Given this list of marker genes YME1L1, DHX15, RBM25, CSNK1A1, SERBP1, UBR7, ARL8B, OTUD4, ANKRD17, SEC22C, MED17, TBC1D15, LARS1, POLDIP3, RSRC2, OCIAD1, FOXJ3, EHBP1, EIF3J, LUC7L2, PRPF8, TOR1AIP1, CHTOP, DMTF1, HIPK1, ATP2C1, C1orf52, ARFGAP1, FBXL5, PPP1R15B, TMEM167B, ARID4B, PCNP, GNA13, SNRNP200 (NCBI Gene Id 692221, small nuclear ribonucleoprotein U5 subunit 200), SENP6, here is a description of the gene set: Neighborhood of CSNK1A1 casein kinase 1, alpha 1 in the GCM expression compendium Human Gene Set: GCM_CSNK1A1 Neighborhood of CSNK1A1 studied in species Homo sapiens